The following is a description of a gene set: Mouse Gene Set: GOBP_REGULATION_OF_ANION_CHANNEL_ACTIVITY Any process that modulates the frequency, rate or extent of anion channel activity. studied in species Mus musculus, and this is the list of marker genes: Cftr (cystic fibrosis transmembrane conductance regulator), Abcb1b, Gopc, Abcb1a, Tcaf1